The following is a description of a gene set: Genes predicted to be targets of miRBase v22 microRNA mmu_miR_6903_5p in miRDB v6.0 with MirTarget v4 prediction scores > 80 (high confidence targets). studied in species Mus musculus Mouse Gene Set: MIR_6903_5P from publication Chen Y, Wang X (PMID 31504780), and this is the list of marker genes: Ppm1k, Clvs2, Hao1, Tox, Tfrc, Ints2, Myc, Zfp750, Apool, Chtf8, Pink1, Lhx9, Trhde, Tmed4, Atp6v1g2, Hdgfl3, Paqr4, Zfhx3, Eml3, Zmynd11, Def8, Mex3c, Gria2, Tent4a, Tmem170b, Zfp113, Ints12, Zfp91, Ubr5, Spata2, Strbp, Prkacb, Ccnh, Stk17b, Arhgap44, Phf20, Gm5141, 5730507C01Rik, Lzts3, Esp1, Fhip1b, Cntn1, Mms19, Relb, Crisp4 (cysteine-rich secretory protein 4), Dido1, Thsd7b, Hes7, Arl5a, Pcdhb9, Hdgf, Ndufaf4, Plekhh1, Tmed9, Akap8, Rgs4, Slc35d3, Clstn1, Zscan29, Tesk2, Ptgfr, Zfp709 (zinc finger protein 709), Sprr2f, Lats1, Ppm1b, Cdh11, Wbp1l, Snn, Arfgef3, Kcnj2, Psat1, Pcgf3, Mkrn1, Mef2c, Stac, Sgpp1, Pacs2, Limch1, Ncam2, Tfcp2l1, Ppip5k1, Cyp26a1, Plaa, Utp4, Pcdh19, Slc25a21, Nt5c3, Ntm, Elmo1, Grid1, Pdzd2, Hook3, Gne, Exph5, Pctp, Ctnna1, Chd9, Bms1, Zfp935, Yipf5 (Yip1 domain family, member 5), Zeb2, Morc2a, 1110059G10Rik, Ctnna3, Prr23a4, Foxp4, Zfp9, Ctu1, Klf1, Strada, Bmp2, Cadm1, Kdm7a, Spag16, Cdh3 (cadherin 3), Ypel5, Phf20l1, Armcx4, Nfic, Gpc6, Gria3, Mapk10, Lrrc4c, Amot, Pappa, Slc30a6, Mboat7, Ska2, Ccdc71, Ammecr1, Gjc3, Slc30a7, Tada1 (NCBI Gene Id 72846), Igll1, Pign, Arhgef28, Rbm18, Cacna1c, Cbll1, Cldn34d, Kit, Gramd2b, Bcas1, Galnt13, Dmp1, Plau, BC048679 (cDNA sequence BC048679), Serpina12, Mansc1, Elovl2, Skida1, Tnpo1, Uevld, Gtf3c4, Tigd3, Stk3, Sord, Abcf3, Ei24, Ablim1, Atg4c, Fam53c, Zmat2, Ttpal, Gtf3c2, Ccdc81, Kcnc1, Nr2c2, Kpna3, Msi2, Gata6, Abhd10, Dpysl3, Dad1, Fam163b (family with sequence similarity 163, member B), Sp4, Ankrd50, Srl, Rnf44, Cd2bp2, Jade3, Ablim3 (actin binding LIM protein family, member 3), Zfp808, Ywhag, Parpbp